The following is a description of a gene set: The increase in size or mass of a lung. In all air-breathing vertebrates the lungs are developed from the ventral wall of the oesophagus as a pouch which divides into two sacs. In amphibians and many reptiles the lungs retain very nearly this primitive sac-like character, but in the higher forms the connection with the esophagus becomes elongated into the windpipe and the inner walls of the sacs become more and more divided, until, in the mammals, the air spaces become minutely divided into tubes ending in small air cells, in the walls of which the blood circulates in a fine network of capillaries. In mammals the lungs are more or less divided into lobes, and each lung occupies a separate cavity in the thorax. Human Gene Set: GOBP_LUNG_GROWTH studied in species Homo sapiens, and this is the list of marker genes: FGF10, FGF7, MIR17HG, SPRY2, TMEM38B, RSPO2